Given this list of marker genes Limch1, Emx1, Fzd1 (NCBI Gene Id 14362), Nfix, Enc1, Neurod6, Serinc5, Emx2, here is a description of the gene set: Mouse Gene Set: HEVNER_VENTRICULAR_ZONE_AND_UP_PROJECTION_NEURON_FATE_COMMITTED_CELLS studied in species Mus musculus from publication Bedogni F, Hevner RF (PMID 34321999) Genes selectively expressed by cells committed to projection neuron differentiation beginning in the ventricular zone, in most cases extending into the subventricular zone, intermediate zone, and cortical plate of embryonic day 14.5 mouse cortex.